Given this list of marker genes VAMP2, FGL2, FAM221A, MAPK8, DNAJC6, ARL8B, ARHGEF38, AHNAK, GCLC, SETD2, AMMECR1, SSH2, RBM33, PAIP2, ECM2, ZCCHC2, PRR11, AKAP11, HIBCH, GGH, ITM2C, DR1 (down-regulator of transcription 1), HSPA9 (NCBI Gene Id 91471), RELA, MPZL2, NMT2, LRRIQ4, TBX5, ANGEL2, MAPK1, XK, HDHD5, GET4, PHF3, B3GALNT1, SGIP1, USP34, CHST1, CCSER2, GPR82, CSDE1, PLAAT2, BACH1, SAMSN1, RASGRP1, RCAN1, GNAI3, GTF3A, GAPT (GRB2 binding adaptor protein, transmembrane), NBEAL1, IKZF1, NFIC, CDC73, CTCFL, GNG12, KPNA3, PLAAT1, FRK, MPP7, HIVEP1, MYLIP, PCDH11X, RAB11FIP1, EYA4, GBP7, RAB8B, BDNF, FBXL14, COL4A4, TMCC1, SGPP1, LMBR1, INSYN2A, PBLD, NAA15, UBE2D1, PTPN21, DDX3X, UNC80 (unc-80 homolog, NALCN channel complex subunit), MED13, RRP1B, ASAP1, HINT3, DCAF17, PANK1, SPMIP4, PDS5B, MAB21L2, UFM1 (NCBI Gene Id 51569), ETFRF1, BCL2L15, CCND2, SLC27A6, ANTXR1, MANEA, REEP3, IL17RD (NCBI Gene Id 54756), LYST, DOCK4, CACNA1I, CD58, DENND1B, MED13L, WDR26, SLC30A9, CACNA2D1, SC5D, N4BP2, YOD1, STX16, SEPHS2, ANKS1A, SLC16A9, BIRC6, MAMDC2, RYBP, AKIRIN1, LATS2, GABPA, ERP44, ATP10B, FMN2, SLC30A4, ALCAM, PHIP, CEP70, ZBTB39, AP3B1, GFRA1 (GDNF family receptor alpha 1), GABRA4, ZMYND11, LIPT2-AS1, TMEM33, SLC12A6, IDS, ORC3, ENTPD1, OLFM3, NUFIP2 (nuclear FMR1 interacting protein 2), QKI, PHAX, NDUFB6, MYO5C, ZMYM2, DNAJC7, SMARCE1, ZNF695, LFNG, ATF7IP2, NIN, NPFFR2, SDE2, MMD, FAF2, TSC22D1, RALGDS, SLC10A3, TMED9, AGL, NDUFS1, CUL4B, TSPAN12, SNAP91, GORAB, CNOT4, APBB2, MED12L, CNOT8, HNF1B, DIMT1, MRPS30, LGALSL, DUSP8, UGT2A3, SLC44A1, PRICKLE2, REV1, PCGF5, YWHAE (NCBI Gene Id 7531), ARF4, SLC33A1, CDS1, MINDY3, NEK4, CRISP3, PLXNA1, ZNF182, DIPK2A, STC2, IKZF2, CHD9, PCDH7, IMMT, ARHGEF12, RAP2A, ZNF454, CPEB1 (cytoplasmic polyadenylation element binding protein 1), PLAC8, MARCHF7, CAPZA1 (NCBI Gene Id 829), RCN2, VPS36, UPRT, ACVR1C, CDKL5, SPOCK3, WDFY1, ANK1, KATNAL1, CDV3, E2F5, KPNA1, YLPM1, BCL11B, ANGPTL1, AKAP6, MORC3, NEFL, DCLK1, LGALS8, CFL2, TSGA10, MAPK6, HOOK3, VWC2, PCSK6, CELF2, PLEKHO2, GPAM, C1orf198, C14orf39, PHF20L1, RNFT1, PPA2, OSBPL10, MIPOL1, MBNL1, TOB1, TCIM, SPINK7, PTAR1, DDX5, ARMC8, SAP30, COMMD3-BMI1, CPB2, CACNB4, SLAIN2, NDUFA12, TM9SF3, ABAT, NRAS (NRAS proto-oncogene, GTPase), PGR, ARMC2, ZNF493, MIS12, BNIP3L, ATG12, SUN1, SETD5, SFPQ, DACH2, TRAFD1, PDK4, LRRTM3, CCT8 (chaperonin containing TCP1 subunit 8), CXCL8, GNPNAT1, ERMP1, TMEM258, KIF2A, ACTN1, SLC35D3, YBX3, RAPGEF6, PPAT, ELK3, TPBG, GPATCH2L, ADAM23, PAK6-AS1, ANKRA2, RAPH1, MMP28, USP24, GATA6, BMI1, ZNF432, ARMC1, DET1, MAP3K1, PAXBP1, ADORA2B (NCBI Gene Id 136), FOXJ3, SLC6A15, DGKH, TRDN, DDIT4, ATP1B1, TMTC4, EPHA5, C4orf3, DPY19L4, NSD2, BCLAF1, RNF111, ATAD2B, RAP1A, PKD1L1, ROCK1, DIO2, PCDHB11, here is a description of the gene set: from publication Chen Y, Wang X (PMID 31504780) studied in species Homo sapiens Human Gene Set: MIR545_5P Genes predicted to be targets of miRBase v22 microRNA hsa-miR-545-5p in miRDB v6.0 with MirTarget v4 prediction scores > 80 (high confidence targets).